Given this list of marker genes GPC1, LRRC15, RPSA, SSC5D, DAG1, SHH, LGALS1, FKRP, ITGB1, RPSA2, ITGA3, BCAM, SLIT2, LACRT, ADGRG6, THBS1, NID1, LYPD3, LGALS3, NTN4, TINAGL1, ITGA2, PXDN, PLEKHA2, AGRN, ADAM9, ACHE, CTSS, here is a description of the gene set: Binding to a laminin, a major glycoprotein constituent of the basement membrane of cells. Human Gene Set: GOMF_LAMININ_BINDING species: Homo sapiens